The following is a description of a gene set: Human Gene Set: GOMF_NADPH_BINDING species: Homo sapiens Binding to the reduced form, NADPH, of nicotinamide-adenine dinucleotide phosphate, a coenzyme involved in many redox and biosynthetic reactions., and this is the list of marker genes: CBR3, KCNAB1, NDOR1, MTRR, CRYZ, SRD5A1, KDSR, GRHPR, HMGCR, LBR, DHFRP1, DUS2, CBR4 (NCBI Gene Id 84869), DHFR, QDPR, CYBB, TP53I3, DECR1